Given this list of marker genes ERP29, PEX6, PEX1, ANGPTL4, HSP90AA1, here is a description of the gene set: The process of assisting in the disassembly of non-covalent linkages in a protein or protein aggregate, often where the proteins are in a non-functional or denatured state. studied in species Homo sapiens Human Gene Set: GOBP_PROTEIN_UNFOLDING